Given this list of marker genes CNGB1, CNGB3, CNGA4, CNGA3, CNGA2, AQP1, CNGA1, here is a description of the gene set: Human Gene Set: GOMF_INTRACELLULARLY_CGMP_ACTIVATED_CATION_CHANNEL_ACTIVITY species: Homo sapiens Enables the transmembrane transfer of a cation by a channel that opens when intracellular cGMP has been bound by the channel complex or one of its constituent parts.